Given this list of marker genes NTRK2, PLAT, MECP2, SLITRK5, PLG, SYT4, here is a description of the gene set: species: Homo sapiens Human Gene Set: GOBP_TRANS_SYNAPTIC_SIGNALING_BY_BDNF Cell-cell signaling between presynapse and postsynapse mediated by brain-derived neurotrophic factor (BDNF) crossing the synaptic cleft.